Given this list of marker genes LINC02511, LINC02466, RPL15P8, RPL7AP28, INTU, NUDT6, AARS1P1, SERF1AP1, RNU6-583P, LINC02462, C4orf33, EEF1GP8, TUBAP10, ENSG00000287951, TARS2P1, LINC01091, LINC02485, ELL2P2, PLK4, SLC25A31, LINC00498, FAT4, LINC00499, HSPA4L, EEF1A1P35, RNU6-224P, LINC00613, RNU1-89P, PES1P1, LINC02379, LINC02479, ENSG00000226655, H3P15, TECRP2, STMN1P2, SNHG27, GAPDHP56, LINC02172, R3HDM2P1, SLC7A11, RPL21P53, LARP1B, PGRMC2, ENSG00000309874, ENSG00000249847, LINC02516, ENSG00000299789, LINC02615, AFG2A, PABPC4L, TMEM248P1, LINC00616, RBM48P1 (RNA binding motif protein 48 pseudogene 1), CDRT15P11, ENSG00000287144, FOSL1P1, ANKRD50, PCDH18, TERF1P3, FGF2, KRT18P54, MIR2054, ABHD18, LINC01256, LINC02465 (NCBI Gene Id 107986313), JADRR, ENSG00000248187, ENSG00000273077, RPS23P2, SCLT1, LINC02510, PPIAP76, MFSD8, PGBD4P4, SNORA70, SPRY1, ENSG00000283432, PCDH10, PCDH10-DT, LINC02377, SLC7A11-AS1, JADE1, RN7SL205P, RPL21P50, LINC02435, ZSWIM5P3, NUP58P1, here is a description of the gene set: Human Gene Set: chr4q28 species: Homo sapiens